The following is a description of a gene set: species: Homo sapiens Human Gene Set: WP_TAR_SYNDROME TAR syndrome, and this is the list of marker genes: PDZK1 (PDZ domain containing 1), MTA1, POLR3G, NUDT17, MITD1, PEX19, PYM1, POLR3F, GNRHR2, UBE2I, SLC34A3, CLCN3, MAGOH, HJV, HAMP, CD247, HDAC2, HLA-B, HLA-A, HLA-G, NFKB1, HLA-C (NCBI Gene Id 5674), PEX11B, SLC22A4, GPR89A, CCAR2, FURIN, NHERF1, EIF4A3, CD160, PIAS3, FARP2, SUMO2, STAT3, CFTR, ITGB1, AKAP10, FLT3, TXN, BRF1, ANKRD35, TNFRSF14, ZFHX3, SIRT1, LCK, EGFR, LAMTOR1, ITGA10, PDZK1IP1, DNM1, BCL2L13, IFNG, MET, HLA-E, CD3D, SLC22A12, HLA-F, CXCR4, RBCK1, POLR3GL, SLK, POLR3C, DDIT4